The following is a description of a gene set: species: Homo sapiens Neighborhood of PCNA Neighborhood of PCNA proliferating cell nuclear antigen in the MORF expression compendium Human Gene Set: MORF_PCNA, and this is the list of marker genes: MSH2, YWHAQ, MCM2, PSMB2 (NCBI Gene Id 5690), FEN1, SUMO1, MSH6, CSNK2B, SRSF1, HSPA9, POLE3, CCT2, SNRPA1, KARS1, SNRNP200, HNRNPA2B1, CHERP, IFT25, KHDRBS1, SRSF3, HNRNPM, U2AF1, UBE2L3 (ubiquitin conjugating enzyme E2 L3), BUB3, USP1, PPM1G, SOD1, SLC25A3, HMGN1, EIF4H, TUFM, FBL, ANP32B, NDUFS3, PRMT1, HPRT1, DEK, RAN, XRCC6, RBMX, H2AZ1, SMC1A, NONO, CTCF, PSMD8, ATP5PF, HNRNPA3P1, HNRNPAB, SRSF9, SET, COPS5, XPO1, MTHFD1, UNG, PCNA, BANF1, NCL, POLR2I, ERH, G3BP1, ATP5MC1, HAT1, MCM7, SNRPE, RAD21, PSMB7, SNRPG, TRIM28, FUS, UBA2, PCLAF, HSPD1, SRP9 (NCBI Gene Id 6726), HSPE1, AURKB, EEF1E1, C1QBP, PARK7, PARP1, CYCS, SYNCRIP, CBX3, SSBP1